The following is a description of a gene set: Human Gene Set: MOHANKUMAR_HOXA1_TARGETS_DN Down-regulated in MCF7 cells (breast cancer) by HOXA1. from publication Mohankumar KM, Xu XQ, Zhu T, Kannan N, Miller LD, Liu ET, Gluckman PD, Sukumar S, Emerald BS, Lobie PE (PMID 17213808) studied in species Homo sapiens Expression of homeobox A1 (HOXA1) results in oncogenic transformation of immortalized human mammary epithelial cells with aggressive tumor formation in vivo. However, the mechanisms by which HOXA1 mediates oncogenic transformation is not well defined. To identify molecules that could potentially be involved in HOXA1-mediated oncogenic transformation, microarray analysis was utilized to characterize and compare the gene expression pattern in response to forced expression or depletion of HOXA1 in human mammary carcinoma cells. Gene expression profiling identified that genes involved in the p44/42 mitogen-activated protein (MAP) kinase activation pathway (GRB2, MAP kinase kinase (MEK1) and SDFR1) or p44/42 MAP kinase-regulated genes (IER3, EPAS1, PCNA and catalase) are downstream expression targets of HOXA1. Forced expression of HOXA1 increased GRB2 and MEK1 mRNA and protein expression and increased p44/42 MAP kinase phosphorylation, activity and Elk-1-mediated transcription. Use of a MEK1 inhibitor demonstrated that increased p44/42 MAP kinase activity is required for the HOXA1-mediated increase in cell proliferation, survival, oncogenicity and oncogenic transformation. Thus, modulation of the p44/42 MAP kinase pathway is one mechanism by which HOXA1 mediates oncogenic transformation of the human mammary epithelial cell., and this is the list of marker genes: GDF15, ABHD2, DUSP6, KIF5C (NCBI Gene Id 7860), ENSG00000291006, SLITRK3, FAM229B (NCBI Gene Id 619208), S100A14 (S100 calcium binding protein A14), ASNS, PKIA, CEACAM6, SNORA68, S100A7, FAXDC2, MGLL, S100P, TNIK, PHLDB2, GPR50, GPC6, TNC, SLC22A15, PROS1, EML1, TYRP1, PLAC1, KLF6, S100A6, RNF150 (ring finger protein 150), HIGD1A, ADGRG2, TXNIP, SYNDIG1, WFDC21P, ZNF853, DSC2, CALCR, EPHA4, LEFTY2, SEMA5A (NCBI Gene Id 9037), ALCAM, ARHGEF37, DENND10P1, DKK3, RBMY1A1, CDH6, ZBTB18, MAP1B, CYP19A1, DIRAS2, SCUBE2 (signal peptide, CUB domain and EGF like domain containing 2), STEAP1, INHBA, C3orf52, ARHGEF4, TRIL, PVT1, MMP3 (NCBI Gene Id 4314), HPGD, MUC1, MUC5AC, USH2A, DDIT3, MYCN, INAVA, TUBE1, GASK1B, CADM1, SLC43A1, PDE8B, CLIC3, APOD, ST8SIA4, AAK1, SERPINA3, FGF12, RASAL1, ANXA1 (NCBI Gene Id 301), IL18, MFAP2, MCMBP, CALML5, CGNL1, TSPO, DYRK4, LTF, NYNRIN, CA2, LRRC49, PLPP1, RAB3B, LINC01102, PLA2G2E, CDK14, HLA-F, RUNX1T1, AVPR1A, TALAM1, TOX3, GALNT12, GRHL3, IGSF3, SLC2A9, LINC01587, RBMXL2, FAM83E, EIF4EBP1, SERPINB5, CKB, NMI, FGG, STEAP2, LRP1B, TNFRSF9, HOXB9, MAFB, ASPN, LAMC2, LINC00869, WLS, AMPH, PLA2G3, ST6GALNAC2, CD1C, SPATA6, GAD1, ARHGAP42, NELL2 (NCBI Gene Id 4753), SHC2, ADIRF, SPINK5, DRD2, FXYD3, SMIM14, BMP7, SPOCK1, TFF3, FLJ12825, NPPB, CLGN, BTC, MAF, PREX2, PTCH2, MAPK13, GTPBP10, JAZF1, CALHM6, PLD1, BEX1, IL4R, ERBB4, BIK, UNC5B, SLC8A1, FOXN1, CENPJ, FGF13, GUCY1A1, XCL1, AREG, RNF39, MATN3, OR1D5, RPPH1, SHANK1, AKR1C1, SGK1, DCAF10, ZNF22, SPINK7, LAMB3, GPX2, FGF11, GPER1, SLCO2A1